The following is a description of a gene set: With the goal of creating a resource for in-depth study of myelopoiesis, we have executed a 2-pronged strategy to obtain a complementary DNA (cDNA) clone set enriched in hematopoietic genes. One aspect is a library subtraction to enrich for underrepresented transcripts present at early stages of hematopoiesis. For this, a hematopoietic cDNA library from primary murine bone marrow cells enriched for primitive progenitors was used as tester. The subtraction used 10 000 known genes and expressed sequence tags (ESTs) as driver. The 2304 randomly picked clones from the subtracted cDNA libraries represent 1255 distinct genes, of which 622 (50%) are named genes, 386 (30%) match uncharacterized ESTs, and 247 (20%) are novel. The second aspect of our strategy was to complement this subtracted library with genes known to be involved in myeloid cell differentiation and function. The resulting cDNAs were arrayed on polylysine-coated glass slides. The microarrays were used to analyze gene expression in primary and cultured murine bone marrow-derived progenitors. We found expression of various types of genes, including regulatory cytokines and their receptors, signal transduction genes, and transcription factors. To assess gene expression during myeloid differentiation, we examined patterns of change during induced differentiation of EML cells. Several hundred of the genes underwent fluctuations in expression level during myeloid cell differentiation. The complete database, accessible on the World Wide Web at http://yale130132115135.med.yale.edu/, allows for retrieval of information regarding these genes. Our microarray allows for genomewide expression analysis of myeloid stem cells, which will help in defining the regulatory mechanisms of stem cell differentiation. Mouse Gene Set: MA_MYELOID_DIFFERENTIATION_DN Genes down-regulated during myeloid differentiation induced by tretinoin (ATRA) and IL3 in the EML cell line (myeloid progenitor). species: Mus musculus from publication Ma X, Husain T, Peng H, Lin S, Mironenko O, Maun N, Johnson S, Tuck D, Berliner N, Krause DS, Perkins AS (PMID 12130493), and this is the list of marker genes: Fosl2, Klf1, Zbtb17, Zfand5, Cd63, Ybx1, Yes1, Ces1c, Notch1, Vav2, Ccl2, Apba2, Smad4, Hoxd12, Eif2ak2, Foxd3, Hbegf, Mid1, Psmc4, Ptpn22, Sh3bp1, Hnf4a, Stat4, Crat (NCBI Gene Id 99316), Fos, Hnf1a, Cited2, Xbp1, Vcam1, Hoxb4, Gna13, Rbpj, Pde1b, Gzma, Kif1b, Cd14, Ctla4, Tlx2, Wfdc18, Serpinb2, Pla2g7, Hspa2, Nfatc3, Ppm1g (NCBI Gene Id 14208)